Given this list of marker genes Abcc9, Mapk1, Mmp9, Smpd3, B2m, Alox5ap, Grin2a, Hpca, Ryr3, Cdkn1b, Syt1, Kcnq3, Shh, Glra1, Alad, Slc12a2, Nlgn1 (neuroligin 1), Iqgap1, Slfn14 (NCBI Gene Id 637877), Cyp1a2, Cpne8, Kcnb1, Hnrnpa1, Fus, Mt2, Nqo1, Fbp1, Lrrk2 (leucine-rich repeat kinase 2), Nfatc4, Creb1, Lce1d, Gsk3a, Atp13a2, Hsf1, Plcg2, Cpne6 (NCBI Gene Id 12891), Aqp2, Jun, Eif2s1, Abcb6, Junb, Adcy1, Sox2, Lig4 (NCBI Gene Id 319583), Foxa2, Cpne4 (copine IV), Mt3, Hfe, Rasal1, Mef2a, Micu2, Nek7, Ppif, Cyp2a5, Zfp616, Jund, Capn3, Add1, Atp7b, Prkaa1, Scn5a, Cebpa, Eef2k, Nptx1, Tfrc, Kcnh1, Akap5, Pkd2, Endog, Nfatc2, Akr1c18, Krt10, Mcoln1, Mapk3, Kcna1, Cpne9, Atp7a, Trpm2, Crhbp, Cldn1, Glra3 (glycine receptor, alpha 3 subunit), Fabp4, Adcy7, Myog, Becn1, Pparg, Sumo1, Tigar, Slc1a1, Wnk1, Calr, Alox15, Wnt5a, Ucp2, Rasgrp2, Itpkb, Mecp2, Aqp1, Ryr1, Hsd17b1, Nfatc1, Chuk, Egfr, Ncstn, Lgmn, Nfe2l2, Micu3, Crp, Micu1, Guca1a, Trf, Atf4, Snca, Kcnj10, Prnp, Ank3, Fn1, Glra2, Dlg4, Mtf1, Rasa4, Id2, Acta1, Neurod2, Dpep1, Mylk, Adcy8, Mef2c, Kcnj1, Gabrb3, Carf, P2rx4, Edn1, Slc11a1, Ptgs2, Slc13a2, Cybb, Bnip3, Cer1, Star, Nrxn1, A3galt2 (alpha 1,3-galactosyltransferase 2), Mapk8, Hspa8, Serpinf1, Cpne7, Bace1, Cyp1a1, Slc13a5, Braf, Stk39, Inhbb, Hmox1, Nfatc3, Tspo, Smpd1, Slc25a24, Mt1, Acer1, Ireb2, Slc41a1, Zfp658, Hvcn1, Th, Cdh1, Ogg1, Fos, Fas, Mt4, Cpne1, Itpka (inositol 1,4,5-trisphosphate 3-kinase A), Mapk9, Dlg2, Prkaa2, Kcnq2, Akt1, Itpkc, Map1lc3a, Bmp6, Gpr39 (G protein-coupled receptor 39), Adgrv1, Chp2, Hesx1, Tlr9, Tfr2, Gsn, Kcnk3, Tuba1a, Nfe2l1, Slc25a23, Tfap2a, Cpne5, Zfp735, Clic4, Fosb (FBJ osteosarcoma oncogene B), Asph, Slc25a39, Gabrg2, Daxx, Ect2, Gpld1, Cpne3, Cpne2, Slc39a8, here is a description of the gene set: Any process that results in a change in state or activity of a cell (in terms of movement, secretion, enzyme production, gene expression, etc.) as a result of a metal ion stimulus. species: Mus musculus Mouse Gene Set: GOBP_CELLULAR_RESPONSE_TO_METAL_ION